Given this list of marker genes ELANE, KLK3, LGALS4, SPINK5, EVPL, MMP7, KLK5, PGC, KLK7, here is a description of the gene set: studied in species Homo sapiens Human Gene Set: GOBP_ANTIBACTERIAL_PEPTIDE_PRODUCTION The synthesis or release of an antibacterial peptide during an immune response, resulting in an increase in intracellular or extracellular levels.